The following is a description of a gene set: species: Homo sapiens Mycobacterium tuberculosis (Mtb), when located in the cytosol of phagocytes, induce cell death similar to necrosis as a means to exit the host cell, ultimately spreading the infection (Moraco & Kornfeld 2014). part of: Escape of Mtb from the phagocyte Reactome Pathway: Phagocyte cell death caused by cytosolic Mtb, and this is the list of marker genes: cpnT